The following is a description of a gene set: Transcripts enriched in pseudopodia of NIH/3T3 cells (fibroblast) in response to haptotactic migratory stimulus by fibronectin, FN1. RNA localization is important for the establishment and maintenance of polarity in multiple cell types. Localized RNAs are usually transported along microtubules or actin filaments and become anchored at their destination to some underlying subcellular structure. Retention commonly involves actin or actin-associated proteins, although cytokeratin filaments and dynein anchor certain RNAs. RNA localization is important for diverse processes ranging from cell fate determination to synaptic plasticity; however, so far there have been few comprehensive studies of localized RNAs in mammalian cells. Here we have addressed this issue, focusing on migrating fibroblasts that polarize to form a leading edge and a tail in a process that involves asymmetric distribution of RNAs. We used a fractionation scheme combined with microarrays to identify, on a genome-wide scale, RNAs that localize in protruding pseudopodia of mouse fibroblasts in response to migratory stimuli. We find that a diverse group of RNAs accumulates in such pseudopodial protrusions. Through their 3' untranslated regions these transcripts are anchored in granules concentrated at the plus ends of detyrosinated microtubules. RNAs in the granules associate with the adenomatous polyposis coli (APC) tumour suppressor and the fragile X mental retardation protein (FMRP). APC is required for the accumulation of transcripts in protrusions. Our results suggest a new type of RNA anchoring mechanism as well as a new, unanticipated function for APC in localizing RNAs. studied in species Mus musculus from publication Mili S, Moissoglu K, Macara IG (PMID 18451862) Mouse Gene Set: MILI_PSEUDOPODIA_HAPTOTAXIS_UP, and this is the list of marker genes: Ppp2r3a, Zranb2, Rab8b, Rtraf, Mrpl47, Carnmt1, Dlg3, Ergic2, Cfl2, Rps6ka3, Txndc9, Znrf2, Gtpbp4, Wbp4, Eif3e, Coa5, Gpbp1, Mapk8, Trp53inp2, Ptpn2, Lgalsl, Hnrnpa3, Wwtr1, Ttc1, Shox2, Ctbp2, Rpap2, Eri1, Smim15, Sarnp, Pdk1, Gnpnat1, Btf3l4, Lsm14a, Dmxl1, Il2, Dnm1l, Ythdf2, Rap2c, Snx5, Eif1a, Ppp3ca (protein phosphatase 3, catalytic subunit, alpha isoform), Sumo1 (NCBI Gene Id 22218), Zfp386, Ythdc1 (YTH domain containing 1), Arl5a, Dek, Rp2 (NCBI Gene Id 19889), Armcx3, Rabep1, Timm8a1, Mbnl1, Clock, Rpl31, Tial1, Zmat2, Borcs7, Rps6ka6, Usp46, Opa1, Exosc9, Yme1l1, Polr1f, Ubr3, Ppp1r7, Ccnc, Rbm34, Kctd10, Slu7, Mkrn1, Yes1, Nudt2, Gtf3c6, Rbbp8, Cttnbp2nl, Ppwd1, Tstd3, Eif2a, Gab2, R3hdm1, Ublcp1, Kras, Mrps22 (mitochondrial ribosomal protein S22), Map2k7, Nfia, Palld, Rflnb, Mycbp, Prim1, Serf1, Mff, Esco1, Fnbp1l (NCBI Gene Id 99918), Txnl1, Uba3, Frg1, Rpf2, Dclk1, Mtap, Nxt2, Cetn3, Ap4s1, Herc4, Mpp7, Aggf1, Skp1, Xaf1, Bmi1, Oxr1, Aasdhppt, Acbd5 (acyl-Coenzyme A binding domain containing 5), Matr3, Lims1, Tank, Taf13, Cyb5r4, Usp24, Tmem263, Cep83, Pdcd5, Metap2, Fyttd1, Rab5a, Nr3c1, Agtpbp1, B230219D22Rik, Ppp1cb, Camk2d, Ube2d3, Hmgn3, Spred1 (sprouty protein with EVH-1 domain 1, related sequence), Tmem167, Dnajb4, Sacm1l, Agfg1, Rab13, Chmp2b, Tigd2, Ptpn4, Yaf2 (YY1 associated factor 2), Pfn2, Iqsec2, Bhlhb9, Dynlt3, Cdc5l, Acsl4, Bclaf1, Trmt11, Tra2b, Serpinb9, Ss18l2, Cyb5r3, Ltn1, Strn, Ptar1, Ppp4r2, Cnot2, Topors, Ints8, Ptp4a2, Fastkd2, Bmt2, Cul3, Plekha8, Cenpu, Rgs20, Ccnh, Srsf3, Btbd1, Nusap1, Tes3-ps, Gm14942, Zfp560, Pum3, Rybp, Trappc8 (NCBI Gene Id 75964), Ap3m1, Cript, Stag2, Hnrnph3, Ott, Cebpzos, Dcaf5, Atr, Dcaf6, Zfp326, Yae1d1, Mllt3 (NCBI Gene Id 77576), Fgfr1op2, Iftap, Nifk, Hibch, Ccdc34, Ppp1r12a, Cop1, Samd4, Tbc1d12, 2610021A01Rik, Uchl5, Zfp277, Slc25a46, Riok3, Vps13a (vacuolar protein sorting 13A), Capza1, Ptp4a1 (NCBI Gene Id 98792), Pkp4, Scp2 (NCBI Gene Id 99990), Ssb (NCBI Gene Id 228007), Abcb7, Snap23, Xpo1, Psip1, Atp6v1d, Actr2, Kpna3, Orc2, Ddx10, Bzw1, 5730409E04Rik, Vti1b, Smco4, Itgb3bp, Cops2, Atf2, Erbin, Ythdf3, Ugp2, Iws1, Ube2d2a (ubiquitin-conjugating enzyme E2D 2A), Irak1bp1, Rps20, Fam229b, Rpe, C1d, Cfdp1, Tbc1d8b, Ywhab, Rasa1, Utp14a, Cenpq, Ccnd2, Slirp, Bub1, Cryzl1, Emc2, Rspry1, Ak6, Nae1, Hif1a, Ttc33 (tetratricopeptide repeat domain 33), Rap1a, Xlr, Npm1, Ccne2, Pja2, Sh3bgrl, Nudcd2, Fxr1, Cul2, Vps54, Qki, Zfr, Lst1, Actr6, Vcpip1, Myef2, Arhgap5, Ate1, Naa50, Cdv3, Rala, Samd9l, Strbp, Fbxw2, Rbis, Camsap2, Wdr75, Cgas, Thoc7, Snx16, Dynll2, Ints13, Cdkal1, Ankrd11, Gkap1, Mib1, Zbtb38, Rnf115, Smc5, Ccdc90b (coiled-coil domain containing 90B), Mfap1a, Srsf1, Larp7, Cyp2c55, Asnsd1, Ddr2, Dpp8, Hdgfl3 (NCBI Gene Id 72589), Arl6, Scrn3, Steep1, Smim13, Inpp1, Fam133b, Ctla2b, Esf1, Gpatch4, Nipbl, Ppfia1, Paip1, Slc4a1ap, Rnf6, Pafah1b1, Psmd6, Mrpl57, Parp4, Trappc2, Ccdc141, Pdss1, Stard4, Hmgcs1, Ncoa2, 1110059E24Rik, Vbp1, Gm4836, Ccng1, Sltm, Hdac2, Hnrnpr, Ivns1abp, Wdr26, Zdhhc2 (zinc finger, DHHC domain containing 2), Eif3j1, 2310010J17Rik, Zeb1, Nap1l1, Smap1, Mbip, Tubgcp4, Ola1, 4930453N24Rik, Chpt1, Sbf2, Ufsp2, Phldb2, Dtna (NCBI Gene Id 68022), Sos1, Zfp24, Eif4g2, Cpsf6, Mak16, Vps4b, Mid2, 1110059G10Rik, Tbc1d15, Irgm1, Eif5b, Mrps18c, Lztfl1, Dynlt2b, Stag1, Trip4, Srp54a, Septin6, Ift74 (intraflagellar transport 74), Thumpd3, Cnot7, Strap, Selenot, Bend6, Cul4b, Kif1c, Dnajc15, Cacybp, Pola1, Mapkbp1, Mob4, Tsr1, Rwdd1, Krr1, Styx, Cfap97, Rpl17, Kif2a, Ankrd13c, Togaram1 (TOG array regulator of axonemal microtubules 1), Ranbp6, Myo5a, Armc1, Commd8, Psmc3ip, Sdhaf3, Cenpp, Celf2, Srek1ip1, Zfp600, Htatsf1, Cab39l, Sanbr, Rab11a, Ifit2, Idi1, Gm6607, Bbip1, Synj2bp, Zfp131 (NCBI Gene Id 72465), Anapc4, Fam13b, Hes5, Ro60, Cisd2, Mef2a, Fbxo32, Pbrm1, Rnf138, Cenpk, Rock1, Mtmr6, Rpl21, Tcf12, Gnl2, Ahsa2, Wwp1, Tax1bp1, Naa15, Mrpl13, Gdi2, Pik3c2a, Kif5b, Mrrf, Apc, Igf2bp2, Dync1li2, Nemf, Trim44, Ssbp1, Zbtb12, Mbnl2, Atrx, Capza2, Dixdc1, Eif2s2, Cox7b2, Abi2, Csnk1g3, Pip4k2a, Cd2ap, Tomm70a, Bclaf3, Snx6 (sorting nexin 6), Mtpn, Pdcd10, Nup54, Rbm41, Gspt1, Wdr43, Srsf11, Efr3a, Ube2v2, Smchd1, Rbm25, Sucla2, Map1b, Pwwp3b, Pno1, Gmps, Myo1h, Vamp4, Far1, Septin7, Msantd4, Pcyt1b, Gulp1, Net1, Tlk2, Bvht, Oip5os1, Zrsr2, Prpf40a, Nampt, Crbn, Rbm7, Hnrnph2, Ube2d-ps, Arpp19 (NCBI Gene Id 72570), Gmfb, Nipsnap2, Cip2a, Tnks2, Tcea1, Dkc1, Ifi204, Tpd52, Ogfrl1, Cenpb, Setd7, Usp16, Ppp4r3b, Mre11a, Chek1, Dock11, D130020L05Rik, Vps35, Chmp1b2, Smc3, Sf3b1, Pcnp, Tut7, Snhg6 (small nucleolar RNA host gene 6), Fndc3a (fibronectin type III domain containing 3A), St13, Ncor1, Tent2, Mtpap, Mrps14, Cavin2, Sh3glb1, Thoc1, Orc3, Cstf2, Psmc6, Stard10, Fkbp3, Cisd1, Vps41, Naa30, Kank2, Hnrnpk, Golph3, Zmynd11, Pphln1, Dnaja1